Given this list of marker genes LILRB4, INPP5D, HMGA2, KLKB1, MIR505, PCSK9, MYOCD, SHC1 (SHC adaptor protein 1), CLEC4A, FN1, ULK1, MIR885, GATA2, MIR15A, SPTBN4, GBA1, GJA5, IL17F, ADAMTS1, HOXC10, ILRUN, TNFRSF11B, VTN, TRIB1, TRPC5, TMX1, CYBA, MIR217, IL1R2, MIR210, SERPINE2 (serpin family E member 2), SOSTDC1, MIR221, PPP3CA, ING2, PRKAR1A, OPRK1 (opioid receptor kappa 1), PTGDS, FIG4, TBC1D10C, ADGRB3, LGR4, IL19 (interleukin 19), STUB1, NPPA (NCBI Gene Id 90230), JAM2, SLC12A2, PDGFA, MAD1L1, ADAMTS18, CTSG, TLR2, CD38, CDKL3, NMI, MIR138-1, UBASH3B, ADRB3, CD160, DAAM2, PRNP (NCBI Gene Id 96713), CD80, SFTPD, PON1 (paraoxonase 1), P2RX4, MIR20B, NDRG2, IL1RL1 (NCBI Gene Id 9173), THBD, ADORA2B, NKX6-1, TIGIT, GDF10, GSK3A, RGMA, CD69, MIR185, RAP1GAP, MIR506, PRICKLE1, GLRX3 (glutaredoxin 3), NR1H2, NDFIP1, NFKBIA, BIN1, MIR873, ITGAV (NCBI Gene Id 7449), GPR174, SMAD3, IL13, KCNK2, ADAMTS9, ANGPTL3, PRKG1, MIR208A, SPRED2, RAG2, GBP1, ACTN3, MSTN, NMBR, ATP1A1, NPTN, PROC (NCBI Gene Id 5624), WNT7A, SERPINB1, DAB1, APCS (NCBI Gene Id 325), AKAP8, ATP1A2, TIFAB, BMAL1 (NCBI Gene Id 406), C1QTNF1, STK39, ZNF423, PRG2, MIR10A, PDCD1LG2, SPN, ACOD1, LIN28A, SARS1, CD2AP (CD2 associated protein), ADM, APP, PLCL2, BGLAP, NPPB (NCBI Gene Id 4879), DUSP3, NKX3-2, MARK1, ATG9A, CRY2, CYGB, TIMP1 (NCBI Gene Id 7076), IL27RA, CD300A (NCBI Gene Id 11314), MIR34C, MIR136, MIR486-1, CX3CR1, ADA, EPHA4, NPY2R, CRH, FBXO11, TNFSF4, BMPR2, EXTL3, PAK1, ADGRB2, CALR, APPL2, C1QC, SEMA3F, GHRL, DIP2B, ROBO2, PCTP, SAP30L, PTPN6, LMNA, TIA1, POU4F2, IL2, USP19 (ubiquitin specific peptidase 19), GATA5, VEGFA, CR1, RPS6KA4 (ribosomal protein S6 kinase A4), PTPN22, HOOK3, KLF4, FFAR4, FOXP3, LEF1, PYDC2, REG3G, GGCX, FOXO1, DDX56, PLK2, HEY2, RSPO2, E2F2, VTCN1, HOXA5, PTGER3, MIR202, MILR1, WWC2, GDF2, EPHA2, PLCL1, TTR (NCBI Gene Id 7276), PRDX2, MIR155 (microRNA 155), MIR372, MIR181C, APOA4, FRZB, ID1, TGFBR1, ANGPT4, NTRK3, ZC3H8, MORC3, KCTD11, EZH2, ANGPTL7, TNFAIP3, ITGB3, ADORA1, RTN4R, SERPINE1, CD83, JAK3, CLNK, MIR573, TRPM4, SYNGAP1, CD274, GPNMB, SCGB1A1, CAV3, FOXA1, ALOX12, APOA1 (apolipoprotein A1), TRPV3, ID4, PTPRR, CIDEA, CD86, TSPAN32, EIF2AK3, HHEX, PTN, SOX11, ATP2B1, NKX3-1, MYCN, MT3, STAT3, MIR205 (microRNA 205), CACTIN, FYN, BRCA2, SDHAF2, ASCL2 (achaete-scute family bHLH transcription factor 2), F2, STAB1 (NCBI Gene Id 23166), TGFB1, DTX1, SLC6A4, GDI1, MYLIP, STC1, SMO, SPINK5, OGT, BCOR, HMGB3, MIR134, TRAIP, SEMA4F, TOB2, CARD17P, LGALS3, ILDR2, SMAD2, CD84, MIR20A, HDAC1, ASB1, ARRB2, THBS1, MDK, SERPINB2, SERPINF1, MTMR2, ARRDC3, SAP30, MACIR, CTSK, PLA2G10, FSTL4, MIR377, PRDX4, ITGA4, VGLL4, ADIPOQ, WNT5A, CGA, COL4A2, ADAMTS12, GATA1, IL17D, YJEFN3 (NCBI Gene Id 374887), TAC1 (tachykinin precursor 1), MIR26B, YPEL4, ROBO1, MIR361, PLA2G2D, IL23R, IFNB1, GPR137B, IL4I1, CTSC, GPR55, TRIM46, KAT8, EFEMP1, RPS6KA6, LAG3, NPR3, GSK3B, MIR215, CD34, IL1B, PIK3R1, ADRA2A, EPHB2, MIR128-1, WNT3, ZNF675, HLX, HAVCR2, IL12A, CUL4A, SULF1, CD200, ZNF683, ENPP3, TGFB2, CST3, SLIT1, DNAJB11, KRT1, LEP, PAX2 (NCBI Gene Id 5076), KLHL22, MIR140, CCN3, FAM76B, OAS3, KIFAP3, IL4R, PTEN, XCL1, FURIN, OSR1, MIR708, TACR2 (tachykinin receptor 2), FOXP1, CBFB, MIR492, MIR26A1, SOCS6, DUSP10, PTGER4, MIR495, GUCY1A1, CDK5, RASSF5, DRD2, IGFBP5, SH2B3, LRRC17, MARCHF7, MIR590, ZNF750, TRIM27, MIR142, GLI3, THY1, HMGB1, FOXA2, IRF1, WNK4, NPR1, CTDP1, GAS6, ATM, OTUD7B, SCT, MIR302C, ELAPOR2, CEBPA, FGL1, MIR193A, STK4, APLN, TMEM176A, IL17RD, PGLYRP1, ID2, ATG5, RC3H2, ABHD6, SAMSN1, WNT10B, WWC3, BTG2, PLA2G2F, GCLC, CST7, TIE1, LPIN1, PTPRM, CD96, ADTRP, COL4A3, BANK1, IL36RN, GBP7, IFNA2, RELA, RNF125, EAF2, TRIM62, GSTP1, MIR129-1, MIR147A, FGR, CHID1, ACOT11, MIR143, INHA, NRP1, EPN2, DAB2IP, OAS1, EFNA1, LTBP3, GIT1, GNRH1, BRMS1L, APOM, TBX21, MIR96, SINHCAF, CXCR3, TACSTD2, INHBE, MIR504, GRN, EFNB3, KLF2, DUSP22, OVOL2, SFRP2, FSHR (follicle stimulating hormone receptor), HDAC7 (NCBI Gene Id 51564), FXN, NLRP2B, TWSG1, ING1, MIR1-1, DAPL1, GFRA4, WWC1, SPP1, MIR15B, PHB2, ACVR1B, HCRT, MIR302D, WNT3A, CD36, MTNR1B, KLF7, DDIT3, ABCG8, EFNA3, ELF4, NKX2-1, ORM1, IL18R1, PAEP, HMOX1, MIR766, GAL, TNFRSF14, MIR27A, STC2, PROS1, FLCN, MIR383, SIRT2, CARD8, ELANE (NCBI Gene Id 6417), ARID4A, NAV3, HDAC6, CCL3, GDF15, GNAS, FGA, FOXE3, WNK1, THBS4, MINAR1, SYNJ2BP, MIR640, LGALS9C, IL2RA, BTK, CASP3, MIR520C, NPVF, PAX8, NLRX1, NFKBIL1, HNF1B, MIR214, MAP2, SPARC, ISM1, PCM1, GORASP1, MIR939, CD63, NR5A1, GPR4, RUNX3, CBLB, ATF4, F2R, MIR329-1, NMU, RARB, PRKACA, PLA2G2A, NPFF, NLRP7, BRINP1, STATH, IL6, RAI1 (retinoic acid induced 1), MIR29C, ARRB1, PTPN23, PPM1B, CREB3L1, STK3, MIR27B, ATP2B4, MAPKBP1, ERRFI1, YY1, PITX3, MLIP, ENPP1, FBLN5, TRIM11, ERBB2, TWIST1, TLE3 (NCBI Gene Id 7090), TNF, CERS1, SLAMF8, RNF10, MIR146B, NR1H4, RBP4, HRG, PROX1, RUFY3, TMEM98, MMP2, TAOK3, RARA, PTPRC, GHSR, FRS2, DOCK4, ANXA2, SEMA4A, FBLN1, EPPK1, TICAM2, LTF, MIR19A, FSTL3, MIR424, MIR378A, ECSCR, VAX1, RBPJ, SAV1, MAFB, ROCK2, RAB11FIP3, TMEM131L, MIR31, CRHBP, TLR4, ABCG5, SRSF6, FUZ, EVL, RFLNB, MIR17, DRAXIN, PTPRO (NCBI Gene Id 5800), DLX1, CLSTN3, YBX3, FBN1, HOXA7, PRTG, BMP4, FOXC1, ADAM17, CCN4, ANGPTL4, SEMA6C, F11, TRPC6, EMILIN1, GLRA1 (NCBI Gene Id 2741), MIR200B, CDH1, FOXJ1, SKI, MIR199A1, RNF128, NR5A2, FGF3, PDGFB, SYT11, ABCB1, FGF23, MIR133A1, MIR197, USF1, CTNNA1, SRGN, IDO1, REG3A, LNPEP, PFN2, ADRB1, GPR137, CRY1, LILRA4, SOD1, NOL3, PML, MIR30C1, TEK, MIRLET7C, TLX2, RB1, TFPI, PTPN2, STK11, GATA3, DLL1, SLC2A10, ACVR1C, LGALS9, FGF8, CTLA4, DRD3, SEMA3E, PTGDR2, LILRB3 (NCBI Gene Id 11025), PRL, MAPK11, RAD21, P2RX7, PRKCD (protein kinase C delta), BANF1, SVEP1, HSPA9, BST2, SELENOS, FER, HLA-G, ZC3H12A, TUSC2, TLR3, IL4, CNR2, SPINK7, MIR92A1, HLA-DRB1, MIR101-1, EZR, F2RL1, IFNL1, BCR, MIR93, RGS4, NCKAP1L, SMAD7, SIRPA, TNFRSF1B, MIR1908, MAP2K5, MIR920, CTDSP1, PAWR, HDAC9, TP53, ZBTB7B, PAX6, FCGR2B, HPN, GLMN, MIR148A (microRNA 148a), NTN1, MIR25, HES5, RAPGEF2, MIR181D, SRC, ECM1, PTK2B, IL6R, AXL, FERMT1, RARG, INS, DPYSL5, HLA-F, ATP2A1, ADCY10, CX3CL1, MIR204, PDE3B, MIR488, HDAC3, PTPN13, BMP5 (bone morphogenetic protein 5, NCBI Gene Id 653), RC3H1, WNT4, APOA2 (apolipoprotein A2), MIR520H, MIR153-1, RHBDD3 (rhomboid domain containing 3), TFF2, NR1H3, PGK1, FKBP1B, NAPEPLD, EGFR, CRTAM, NRARP, SPSB3 (splA/ryanodine receptor domain and SOCS box containing 3), TSC22D1, OPTC, CUEDC2, MIR379, NR2E1, TNFSF18, GPR37L1, LGALS9B, MIR302B, MIR520B, PDCD4, ARG2, PIK3CG, ULK2, GADD45A, RAC1, FOXO4, ADRB2, PLAUR (plasminogen activator, urokinase receptor), LILRB2, CD200R1, ZFPM1, BCL2, NPSR1, SOX10, MIR24-1, MIR222, NGFR, YWHAH, CCR1, PLAC8, HS3ST5, AGER, MERTK, HLA-E, SMAD6, MIR1298, MIR105-1, CHADL, ADAMTS7, CD24, N4BP1, ABCD2 (ATP binding cassette subfamily D member 2), PPARA, TAFA3, RBBP7, APOE, EPHA7 (NCBI Gene Id 2045), FGFR1, TMEM53, NODAL, FFAR1, CPB2, BBS2, AGTR2, MSX2 (msh homeobox 2), ANGPT1, DACT3, MUL1, LAPTM5, MIR203A, ATG12, RPS19, ARG1, WNT9A, ALPK2 (NCBI Gene Id 115701), PPARG (NCBI Gene Id 5468), JAK2, ABCC8, TNFRSF1A, MIR181A2, TOMM70, PDGFRA, SPX, MIR125B1, SPRY1, MIR135A1, MIR30E, NOG, FGL2, HDAC2, MIR28 (microRNA 28), C1QTNF3, KRIT1, ATP2A2, FGF13, INHBB (inhibin subunit beta B), SOCS1, UFL1, PI16, IL12B, MIR192, MIR302A, SPRY2, IFRD1, NFIB, FOXJ2, LYN, MIR29B1, IL15, SEMA5A, NAXE, PLXNA3, SDC4, PIAS3, RAB11FIP5, ANGPT2, MIR130A, TCTA, RFLNA, LBP, PYDC1, SCRIB, SOX15, ACVR2B, MIR106A, NOVA2, LAMA4, BMP7, RUNX1, VSIG4, HPGDS, SORL1, APOH, TARM1, MIR199B, CEACAM1, KREMEN2, LRRC32, HIF1A, ERBIN, PGLYRP2, MIR320A, CCN6, GP1BA, ADIPOR1, PTCH1, RPS6KA5, THBS2, GPR18, MIR200C, AVPR1A, BRMS1, TLR6, CPTP, RYK, CMKLR1, ADRA1A (adrenoceptor alpha 1A), REL, PGLYRP3, LRP4, BCL3, FAP, DLL3, NKX6-2, IL31RA, FBXO7, FGG, MIR30B, GPATCH3, GTF2I, MAD2L2, ACOT13, DCN, MIR107, SEMA3G, KREMEN1, CDKN1B, CLDN18, PDE4D, TNNT1, SLAMF1, SPRED1, SMAD4, APOC3, RBX1, XAF1, MIR494, MIR98, AVP, APOD, BCL6, CARD18, LRPAP1, MIR657, MIR874, MIR877, DICER1, HGF, CCR7, ATF2, RABGEF1, WNK3, CALCA, CALCR, ADCY7, INHBA, LGMN, MCC, SOCS5, SFMBT1, TRIB2, PPP1R11 (NCBI Gene Id 9160), SERPING1, RETN, G6PD, MIR149, CBLN1, ADAMTS5, GDF5, IKBKB, CARD16, PF4, LAX1, ARHGDIB, SIN3A (NCBI Gene Id 25942), ITGA9, WT1, IFNGR1, HOMER2, TMEM178A (transmembrane protein 178A), PLN, IRAK3, NLRP6, DLG1 (NCBI Gene Id 1739), GJA1, NR1D1, ADGRB1, CYLD, TYROBP, ITCH, TRAF3IP1, MIR206, PYCARD, PHF14, QKI, PTPN11, SOCS2, FZD7, SRF, TET1, EDN1, UCN, MIR365A, GREM1, CLEC12A, SLC11A1 (solute carrier family 11 member 1), PRKCA, BPI, NPLOC4, MIR19B1, SYT4, BTLA, PRDM16, TNFAIP8L2, KCNK9, ATOH1, NF2, CEBPB, MC1R, MIR29A, NEUROG1, HSPG2 (NCBI Gene Id 7796), SOX6, POMC, CD74, RNF216, SOST, JARID2, MAP2K6, PAG1, GPR68, PIBF1, SFRP1, PTH (NCBI Gene Id 5741), BMP10, AHSG, MIR137, ZNF706, VASN, MIR935, IDH2, MIR195, APLNR, MCF2, LDLR, MIR106B, NOVA1, MIRLET7F1, ARHGAP4, TNMD, IL10, TNFRSF13B, MIR503, CCR2, SPRED3, HMGCR (3-hydroxy-3-methylglutaryl-CoA reductase), C5AR2, SEMA6D, CTNNB1, B2M, VSIR, CHRNA7, UFD1, IP6K1, SPI1, WDR77, MIR100, GRK2, NMB, TRIM63, CERS2, OTUD5, PDCD1, CCL11, ITGB1 (NCBI Gene Id 3688), SEMA6A, NLRP12, RNF6, TFE3, LILRB1, IL33, PTPRS, SOX9, MIR411, ZNF354C, RHEB, HGS, LRFN5, CNMD, MIR375, TNFAIP6, APOC1, ALOX5, SRI, NLRC3, MARVELD3, PTHLH, RAB11FIP1, WNT9B, LDLRAD4, MIR181B1, USF3, DOCK5, MIR520G, ANXA5, LILRA5, ROCK1, ZFPM2 (zinc finger protein, FOG family member 2), SOX8, CLEC4G (C-type lectin domain family 4 member G), TMEM119, PELI1, NFATC4, MIR373 (NCBI Gene Id 442918), GATA6, MECP2, DLG5, SIGLEC1, MIR145, ADGRF5, DYNLT1, CTNND1, TP73, IRAG1, MIR223, MIR212, CUL3, BMPR1A, RGCC, CDK6, MIR132, KLK3, ALDH1A1, MIR21, NLRP3, SNAI2, MIR34B, CDH3, ZFP36, CDKN2A, IAPP, AGO1, BMP2, FOXC2, LST1, TNFRSF21, PLA2G3, RGS2, HSF1, DKK4, IRGM, KIAA0319, KHSRP, SAP130, LGALS1, GPER1, FASLG, PARP1, PIK3CB, HAMP, RNLS, DKK1, MIR146A, NF1, PLA2G5, PDE4B, RELB, TLR8, TSPAN8, STARD13, ARHGAP42, LHX2, IFNG, ACP5 (NCBI Gene Id 54), PLG, TNR (tenascin R), LOXL2, MIR6869, ANXA4, MIR18A, SUDS3, TMEM176B, IL37, MIR338, TTC21B, TYRO3, TREM2, DCC, BCL11A, MIR194-1, DLX2, REST, HOMER3, CSK (C-terminal Src kinase), IHH, AMOT, TAFA5, SERPINF2, TGFB3, NFKB1, NRDC, PLAT, KAT5, SSC5D, CRYBA1, CD37, MIR16-1, MYC, FXR1, TAC4, ADORA2A, PGAM5, SLC4A2, C1QBP, BMP3, MIR125A, FBXW7, RIPOR2, MNDA, PPP2CA, SHH, CORO1C (coronin 1C), PSEN1, DCANP1 (dendritic cell associated nuclear protein 1), GJD3, F12, CHSY1, SREBF2 (sterol regulatory element binding transcription factor 2, NCBI Gene Id 6721), MEF2C, ERFE, DOCK7, IL23A, TP63, FGB, LUC7L, EPN1, GPR149, SIGIRR, APOC2, TSKU, MEFV (NCBI Gene Id 4210, MEFV innate immunity regulator, pyrin), MIR17HG, DSG2, IGF1, MIR34A, KNG1, ARID4B, TSPO, RTN4, PSG9, ANXA1, CYP51A1, CD300LF, CXCL10, PARP3, VSX2, IL20RB, HFE, MIR487B, TBX5, LAPTM4B, CD33, PKN1, NOS3, CARTPT, MICA, LOXL3 (NCBI Gene Id 84695), DEFB114, TRAK2, STAT1, NOTCH1, STAT5A, ZBTB46 (zinc finger and BTB domain containing 46), MIR144, CNTF, BTN2A2, MIR152, PLAU (NCBI Gene Id 95176), ABCD1 (NCBI Gene Id 215), CD9, PROCR, CLDN5, RBBP4, WNT11, EPX, SPART, PTPRG, VASH1, DHX58, HES1, MAG, here is a description of the gene set: Any process that stops, prevents, or reduces the frequency, rate or extent of an organismal process, the processes pertinent to the function of an organism above the cellular level; includes the integrated processes of tissues and organs. species: Homo sapiens Human Gene Set: GOBP_NEGATIVE_REGULATION_OF_MULTICELLULAR_ORGANISMAL_PROCESS